Given this list of marker genes CS, HSPE1, MALAT1, TFE3, MDH2, SLC19A2, FH, NONO, NMRK2, here is a description of the gene set: LncRNA-like NMRK2 in translocation renal cell carcinoma species: Homo sapiens Human Gene Set: WP_LNCRNALIKE_NMRK2_IN_TRANSLOCATION_RENAL_CELL_CARCINOMA